Given this list of marker genes SOCS5, PLEC, ABL1 (ABL proto-oncogene 1, non-receptor tyrosine kinase), PKD2, PRKACG, PTK2B, CAPN2 (calpain 2), MAPK7, PKN2, KLF2, PTPN1 (protein tyrosine phosphatase non-receptor type 1), HAS2, PDPK1, PRKACB, GNAS, ASS1, PRKACA, SREBF2, KLF4, MTOR, MMP2, MAP2K5, XBP1, PPP2CA, HDAC3, MEF2C, MIR92A1, SRC, PTGS2, PTK2, MIR126, NFE2L2, MTSS1, AKT1, here is a description of the gene set: species: Homo sapiens Any process that results in a change in state or activity of a cell (in terms of movement, secretion, enzyme production, gene expression, etc.) as a result of a fluid shear stress stimulus. Fluid shear stress is the force acting on an object in a system where the fluid is moving across a solid surface. Human Gene Set: GOBP_CELLULAR_RESPONSE_TO_FLUID_SHEAR_STRESS